The following is a description of a gene set: Genes down-regulated in myeloid dendritic cell 7d vs 0d in young adults (18-50) after exposure to Fluarix/Fluvirin, time point 7D Here we have used a systems biology approach to study innate and adaptive responses to vaccination against influenza in humans during three consecutive influenza seasons. We studied healthy adults vaccinated with trivalent inactivated influenza vaccine (TIV) or live attenuated influenza vaccine (LAIV). TIV induced higher antibody titers and more plasmablasts than LAIV did. In subjects vaccinated with TIV, early molecular signatures correlated with and could be used to accurately predict later antibody titers in two independent trials. Notably, expression of the kinase CaMKIV at day 3 was inversely correlated with later antibody titers. Vaccination of CaMKIV-deficient mice with TIV induced enhanced antigen-specific antibody titers, which demonstrated an unappreciated role for CaMKIV in the regulation of antibody responses. Thus, systems approaches can be used to predict immunogenicity and provide new mechanistic insights about vaccines. species: Homo sapiens from publication Nakaya HI, Wrammert J, Lee EK, Racioppi L, Marie-Kunze S, Haining WN, Means AR, Kasturi SP, Khan N, Li GM, McCausland M, Kanchan V, Kokko KE, Li S, Elbein R, Mehta AK, Aderem A, Subbarao K, Ahmed R, Pulendran B (PMID 21743478) Human Gene Set: NAKAYA_MYELOID_DENDRITIC_CELL_FLUARIX_FLUVIRIN_AGE_18_50YO_7DY_DN, and this is the list of marker genes: AKAP8L, CENPF, CBFA2T2, AFF4, NCKIPSD (NCBI Gene Id 51517), PDLIM5, OTUB1, AUTS2, MRPS18B, MFNG, ARHGEF9, MLX (NCBI Gene Id 6945), TK2, SSBP2, NME6, DIAPH2, U2AF2, MPHOSPH9, DHX9, SF3A2, NOP14, KDM5A, DMXL2, ZFC3H1, USB1, HADH, PUS3, PRKACA, TXLNG (NCBI Gene Id 55787), NUP88, CD164, COPS2, MSL1, MGMT, CEBPD, SUMO3, PLCB1, KIF2A, QTRT1, TAB1, SFRP1, SNRPN, IL13RA1, TAF6, IDS, COX11, PJA2, SLC26A2, ARHGEF7, DMAC2L, YLPM1, DUS1L, MORC3, NR3C1, MAPKAPK2, PPP2R5D, RNF146, KHDC4, SCARB1, DHX29, MDM2, HBB, PARVB, ARL3, SMARCA4, CDYL, EXT2, NKAPD1, PTPN12, FNBP1, TINF2, GPN1, HK1, RRM2, TCF20, CTSA, WDR1, NIF3L1, GNB5, IL1RAP, PDHB, LAMP1, TOX4, YJU2, MEF2D, RRBP1, CCNJ, EPS15 (epidermal growth factor receptor pathway substrate 15), DMD, ENOX2, ITGB1, ZNF3, MAP9, OPA1, PAK2, GAS7, SMC6, INO80D, OTUD4, SIT1, PRDX1, TXNL4A, RAB11B, PSMD11 (NCBI Gene Id 5717), RAB11FIP2, CLN8, ORC5, TLR6, DVL1, HNRNPC, ZNF609, ATF7IP, ANKRD17, ZNF331, PRCC, RPS6KA4 (ribosomal protein S6 kinase A4), TRAF5, DLAT, CXCR4, SLC7A1, CDK4, PALS2, SNURF, TRGV5, AMMECR1, KLHL7, SAR1A, IGHM, HIF1AN, CHST10, AGPAT3, CHD4 (NCBI Gene Id 1108), PIK3C3, HIGD1B, BCL2, TMCO6, ARHGAP26, PIK3R4, CCND2, CBL, ATP8A1, ATP2B4, ING3, KCNE1, TGOLN2, DAB2, SEMA4D, TBK1, CD47, ARL4C, SORD, FOXN3, SWAP70, UBXN1, FAS, MTMR1, KLHL22, CASK, RPP25, CENPN, PFAS, PIGC, STX6, ZBTB25, IDH3G, SLCO3A1, SLC39A8, ARNT, EIF2S1, BIRC5, ZNF93, RNF24, ITGB3, LILRA5, EHBP1L1, UBXN8 (UBX domain protein 8), CTSB, TEX28, SLC44A1, HUWE1, INSIG1, N4BP2L2, CDC42BPA, ZC3H14, POLG, SNX1, BRWD1, CES2, PHKB, MAP4K5, CC2D1A, GNA13, TTC3, PPIL6, TBC1D13, PKP2, LDLR (low density lipoprotein receptor), UCHL3, BTN2A3P, SIRT5, PHTF1, PHEX, MTMR10, EIF5B (eukaryotic translation initiation factor 5B), H2BC13, SRP72, CDHR5, ST20, KRT5, JUP, CKS1B, LRBA, TRAF3IP3, BLNK, TFDP2, GPD1L, ZNF589, SLC35D1, RCOR3, EZR, ZC3H15, MXRA7, MFSD6, NF2, UBE2G1, PPP2R1B, PRR14L, MAU2, SCCPDH, DIAPH2-AS1, TCF4, C2CD3, ATP6V0A1, PEPD, PTGIR, LRRFIP2, TOMM22 (NCBI Gene Id 56993), SIDT1, HAUS5, CAMSAP1, PANK3, IGKC, MAN1A2, NEK1, HES1, OTUD3, PRDM2 (PR/SET domain 2), PTPN11 (NCBI Gene Id 84990), DBN1, POP5, CHD8, RIOK3, GLS, SLC14A2, DLG1, PHC1, VEZF1, ICOSLG, SRGAP3, AQP3, SMAD3, IPO8, TCP11L1, GTPBP8, GLTP, RUBCNL, RTF1, JADE3, SSRP1